The following is a description of a gene set: The progression of the venous blood vessel over time from its initial formation to the mature structure. Venous blood vessels carry blood back to the heart after the capillary bed. Mouse Gene Set: GOBP_VENOUS_BLOOD_VESSEL_DEVELOPMENT species: Mus musculus, and this is the list of marker genes: Heg1, Eng, Vegfa, Notch1, Foxf1, Acvr2b, Pitx2, Chrd, Acvrl1, Sema3c, Efnb2, Ephb4, Bmpr2, Ccm2, Nkx2-5, Tbx20, Ccbe1, Notch4, Aplnr, Prox1